Given this list of marker genes PCNA, RFC4, FEN1, MCM2, POLA2 (NCBI Gene Id 23649), CCNC, POLD1 (DNA polymerase delta 1, catalytic subunit), TOP2A, TYMS, MCM6, RPA2, here is a description of the gene set: The transcription factor E2F-1 plays a pivotal role in the regulation of G1/S transition in higher eukaryotes cell cycle. We used a cell line containing an inducible E2F-1 and oligonucleotide microarray analysis to identify novel E2F target genes. We show that E2F-1 up-regulates the expression of a number of genes coding for components of the DNA replication machinery. Among them is the gene coding for the 32 Kd subunit of replication protein A (RPA2). Replication protein A is the most abundant single strand DNA binding complex and it is essential for DNA replication. We demonstrate that RPA2 is a novel E2F target gene whose expression can be directly regulated by E2F-1 via E2F binding sites in its promoter. In addition, expression of Topoisomerase IIalpha and subunit IV of DNA polymerase alpha is also up-regulated upon E2F-1 induction. Taken together, these results provide novel links between components of the DNA replication machinery and the cell growth regulatory pathway involving the Rb tumor suppressor and E2F. DNA replication genes up-regulated in a Rat-1a cell line (fibroblast) by expression of E2F1. species: Homo sapiens from publication Kalma Y, Marash L, Lamed Y, Ginsberg D (PMID 11313881) Human Gene Set: KALMA_E2F1_TARGETS